The following is a description of a gene set: Genes predicted to be targets of miRBase v22 microRNA mmu_miR_669d_5p in miRDB v6.0 with MirTarget v4 prediction scores > 80 (high confidence targets). species: Mus musculus from publication Chen Y, Wang X (PMID 31504780) Mouse Gene Set: MIR_669D_5P, and this is the list of marker genes: Esp36, Tcf24, Col4a3, Thrb, Cdyl, Aldob, Slc25a31, Hnrnpu, Cyp27b1, Per2, Pcdh7, Ago1, Acbd5, Smad7, Zfp759, Sri, Pik3ip1, Zfp773, Zfp930, Spats2l, Fdx1 (NCBI Gene Id 14148), Slc25a20, Foxd1, Csgalnact1, Blzf1, Rab7, Sh2d1a, Izumo3, Rora (RAR-related orphan receptor alpha), Hipk3, Ttc27, Or14j9, Kcnip4 (NCBI Gene Id 80334), Pdzd4, Tbk1, Neu3, Plekhm3, Phf3, BC030500, Zbtb10, Id2, Zfp458, Zfp738, Mgat4a, Emc7, Tbx22, Foxo1, Ubp1, Slc28a2b